The following is a description of a gene set: Genes in the cancer module 471. studied in species Homo sapiens Human Gene Set: MODULE_471, and this is the list of marker genes: GCLM, LAP3, CBS, ASNS, SHMT2, ACSL1, ME3, SDS, ME2, GCLC